The following is a description of a gene set: Aplasia, that is failure to develop, of the ovary. Aplasia of the ovary studied in species Homo sapiens Human Gene Set: HP_APLASIA_OF_THE_OVARY, and this is the list of marker genes: PTPN11, PMM2, AR, TP63, HROB, PSMC3IP